The following is a description of a gene set: Polymorphonuclear leukocytes (PMNs) were obtained from healthy individuals in accordance with protocols approved by the Institutional Review Board for Human Subjects at the University of Minnesota and the National Institute of Allergy and Infectious Diseases. PMNs (107) were combined on ice with live S. aureus (108) or with live or heat-killed A. phagocytophilum (bacteria isolated from 5x106 infected HL60 cells for a ratio of 1 infected HL60 cell: 2 PMNs, ~ 5-20 A. phagocytophilum: PMN) in wells of a 12-well tissue culture plate (pre-coated with 20% autologous normal human serum). Unstimulated control assays received either buffer (for S. aureus comparisons) or clarified HL60 lysate (for A. phagocytophilum comparisons). Plates were centrifuged at 350 x g for 8 min at 4oC to synchronize phagocytosis and incubated at 37 deg. C in a CO2 incubator for the indicated times. At the indicated times, tissue culture medium was aspirated from the plate and PMNs were lysed directly with RLT buffer (Qiagen, Valencia, CA). Purification of PMN RNA and subsequent preparation of labeled cRNA target was performed as described in Methods. Labeling of samples, hybridization of cRNA with HU133A oligonucleotide arrays (Affymetrix, Santa Clara, CA), and scanning were performed according to standard Affymetrix protocols ( http://www.affymetrix.com/pdf/expression_manual.pdf ). Experiments were performed in triplicate, using PMNs from three healthy individuals for each treatment. species: Homo sapiens from publication Borjesson DL, Kobayashi SD, Whitney AR, Voyich JM, Argue CM, Deleo FR (PMID 15879137) Genes up-regulated in polymorphonuclear leukocytes (24h): treated by heat killed HC60 cell (promyelocytic leukemia) lysate versus A. phagocytophilum infection. Human Gene Set: GSE2405_HEAT_KILLED_LYSATE_VS_LIVE_A_PHAGOCYTOPHILUM_STIM_NEUTROPHIL_24H_UP, and this is the list of marker genes: CHST11, NAPSA, TTC39A, PLD4, COL4A2, FCER1G, TTC39C, FOXN1, STAP2, HPGD, CDC42EP3 (NCBI Gene Id 10602), IRF6, ESRP1, CYFIP1, CTNNA1, ALAS1, MMP9, DECR1, LAMC2, HSD3B7, SYNGR2, VCL, SERPINB1 (NCBI Gene Id 1992), GNS, NEK6, HIP1R, LGALS3, CSF1R, MGP, CACHD1, SHISA4, NUAK1, FABP5, AADAC, LY6D, MFGE8, ITM2C, RNF216, FSCN1, TAGLN, CCL5, SLCO2A1, KRT5, TMEM26, GPX1, NCF2, PARD6G, HSPA1B, TBATA, ACTG2, ARHGAP44, GNB4, RGS12, RBP1, ANXA1, GPC1, SFRP1, TEC, HEY1, CCL22, ATRNL1, INF2, DUSP4, CD68, CLU, ABHD4, DBNDD2, P2RX4, TRIM29, ARNT2, SRGN, DUSP3, GADD45B, ABCC1, HTRA1 (HtrA serine peptidase 1), PLIN2, MAP3K20, PALLD, HMGN3, ST14, LONRF1, SCG5, IGKC, GNB3, PMP22, PARM1, KCTD15, PLTP, CDH1, JCHAIN, IFI30, IGFBP3, GJA1, PAPSS2, PRNP, C3, S100A4, ICAM1, HFE, CYB561A3, MS4A7, GSTT1, SOWAHB, NRP2, HEXB, APLP2, OGFRL1, MAP1LC3A, MCF2L, IFITM3, CST3, LRP1, STX7, TNFAIP2, PRR13, RGS5, WFDC2, MISP, AXL, BCL2A1, LY86, CSTB, TMEM51, CD86, SLC6A8, FN1, COPZ2, C2, CXCL9, HLA-DOA, LRRK1, MARCKSL1, SMAD1, GRN, SLC44A1, CD83, TMEM176A, ROGDI, S100A6, ISCU, FNDC3B, GMPR, USP18, CCDC90B, ANGPTL2, TPM2, PFN2, CASP4, GRK5, PLEK, SLC6A4, PLAGL1, HLA-DQA1, EML6, ASNS, RNH1, MAGED1, MYH11, SERPINB9, RELB, RNF19B, IRF8, ANXA2, PSAP, LIPH, ALCAM, ANXA4, EHD4, GRB10, PLAAT3, RHBDL3 (rhomboid like 3), LITAF, PSTPIP2 (NCBI Gene Id 9078, proline-serine-threonine phosphatase interacting protein 2), SPECC1, IFT43, DOK1, KRT7, CTBP2, TMC4, SKAP2, ARHGEF16, PKP4, MMP23B, AHNAK, GALNT18, CSRP2, SWAP70, TSC22D1, GNG11, KIAA0930, PKP1, PGAP4, EFHD2, CLEC7A, TP53INP2, TSPAN3, ATP6V0B, PLPP1, LPCAT2, WFIKKN2